Given this list of marker genes PER1, NEU1, ZFP36, NPC2, VMP1, UBE2V1, MAP1LC3B, ATP5F1D, here is a description of the gene set: The short-chain fatty acid butyrate, produced by microbial fermentation of dietary fiber in the large intestine, is a physiological regulator of major pathways of colonic epithelial cell maturation: cell cycle arrest, lineage-specific differentiation, and apoptosis. Microarray analysis of 8,063 sequences demonstrated a complex cascade of reprogramming of SW620 colonic epithelial cells upon treatment with butyrate characterized by the progressive recruitment of gene sets as a function of time. Comparison with the effects of trichostatin A, in conjunction with differences in the kinetics of alteration of histone acetylation induced by butyrate and trichostatin A, identified subsets of induced and repressed genes likely coordinately regulated by altered histone acetylation. The butyrate response was also compared in detail with that of sulindac, a nonsteroidal anti-inflammatory drug with significant chemopreventive activity for colon cancer, and curcumin, a component of mustard and curry structurally and functionally related to sulindac that also has chemopreventive activity. Although gene clusters were identified that showed similar responses to butyrate and sulindac, the data were characterized by the extensive differences in the effects of the two agents. This was striking for functional classes of genes involved in signaling pathways and in cell cycle progression, although butyrate and sulindac induce a similar G0-G1 arrest, elevation of beta-catenin-Tcf signaling, and apoptotic cascade. As regards cell cycle arrest, the underlying mechanism in response to butyrate was most similar to that of the Caco-2 cell line that had spontaneously undergone a G0-G1 arrest and least similar to the G2-M arrest stimulated by curcumin. Thus, high-throughput microarray analysis of gene expression profiles can be used to characterize and distinguish the mechanisms of response of colonic epithelial cells to physiological and pharmacological inducers of cell maturation. This has important implications for characterization of chemopreventive agents and recognition of potential toxicity and synergies. The data bases, gene clusters, and analyses are available at http:// sequence.aecom.yu.edu/genome/. from publication Mariadason JM, Corner GA, Augenlicht LH (PMID 10969808) Cluster 2: genes up-regulated in SW260 cells (colon cancer) by sodium butyrate, curcumin, sulindac and TSA. Human Gene Set: MARIADASON_RESPONSE_TO_BUTYRATE_CURCUMIN_SULINDAC_TSA_2 studied in species Homo sapiens